Given this list of marker genes RNU6-394P, EDA2R, MIR223HG, NANOGP9, MIR223, RNU6-1225P, FRMD8P1, MSN, HEPH, MTFR1P1, LAS1L, AP1M2P1, ETF1P3, YIPF6, TLE1P1, PKMP2, ATXN7L3P1, OPHN1, AR, BMI1P1, CCNYL5, EIF4BP9, PGK1P1 (NCBI Gene Id 5231), RBMXP5, VSIG4, AKIRIN1P2, here is a description of the gene set: species: Homo sapiens Human Gene Set: chrXq12